The following is a description of a gene set: from publication Hu X, Chung AY, Wu I, Foldi J, Chen J, Ji JD, Tateya T, Kang YJ, Han J, Gessler M, Kageyama R, Ivashkiv LB (PMID 18976936) Human Gene Set: GSE11864_UNTREATED_VS_CSF1_IN_MAC_UP Gene expression analysis of freshly isolated CD14+ human monocytes and monocytes cultured in the presence or absence of interferon (IFN) -gamma for 24 h and then stimulated with Pam3Cys, a Toll-like receptor (TLR) 2 ligand, for 6 h. Results provide insight into mechanisms by which IFN-gamma reprograms early macrophage differentiation and subsequent response to TLR ligands. Genes up-regulated in comparison of untreated macrophages versus those cultured with M-CSF. studied in species Homo sapiens, and this is the list of marker genes: C6orf58, PTK2, PGM1, SAMD4B, TGFB1, GOLM1, ATG4B, RWDD1, THOC5, EAF2, STEAP4, PTPN18, KBTBD11, SESN2, HNRNPK, ALDOC, TAFAZZIN, RYK, OLFML1, FDPSP2, SSX2IP, CD300LF (CD300 molecule like family member f), KCNMB1, TAF9B, FAM174B, KLF13, MZT2B, SF3B5, MTA1, RPS3, DNAJC10, EVI2B (ecotropic viral integration site 2B), FLT3, SRSF5, PEX16, PMPCB, ARHGAP15, PABIR3, SLC41A3, MEGF9, ALAS2 (NCBI Gene Id 90735), CMPK1, RELA, TPT1, RPS6, ARHGEF1, ZC3H15, LMNB1, KLHDC4, PSMA1, RPIA, HGS, CD52, TEX47, DOCK2, PLCB1, NFYC-AS1, ITPK1-AS1, ANKHD1, PIWIL4, HLX, ATP5MG, RPL37A, PLAAT4, FAM168B, CCDC6, PYM1, FAM200B, TXLNGY, PLN (NCBI Gene Id 5350), RPS9, INPP4B, HIC2, LYZ, DPYD, CREB5, P2RX1, ARPC1B, RPS28, GMFG (NCBI Gene Id 9535), ENPP6, PHB2, UBE2D3, NME8, IRAG2, UBA7, ZNF296, RAB1B, VCPKMT, STYXL2, NET1, GNB1, HHEX, CYC1, NOP2, CCDC181 (coiled-coil domain containing 181), PRKRA (protein activator of interferon induced protein kinase EIF2AK2), FASTK, MALT1, RPL35, ASGR1, RPL19, DOCK8, PDCD6P1, ACTR1A, SERTAD2, FOSL2, CCL17, RASGRP4, EEF2, RASGEF1A, EOLA1 (NCBI Gene Id 91966), SLAIN2, IFT81, ZNF598, HIPK2, TSTD2, FAM136A, HNRNPA3, ANXA1, SNHG32, SLITRK2, GAB2, LINC00877, RNF139, CDK2AP1, MIR1-1HG, HNRNPM, USP39 (NCBI Gene Id 10713), C4orf33, LIN7A, SKIC8, SMAD2, NAA10, UBXN11, CPA6, GTPBP4 (NCBI Gene Id 23560), MAN2C1, P4HA1, NTNG2, TP53INP1, CHMP1B, SPI1, ATG2A, RPL36A, ZDHHC3, POC1B, APOBEC3G, P2RY13, IZUMO1, IL12A, PSMD13, CENPC, GABARAPL1, TMEM87B, LRRC25, HDDC2, NOMO3, TMC6, SYNE3, CD300LB, HERPUD1 (homocysteine inducible ER protein with ubiquitin like domain 1), TAGAP, PTBP2, CHPF2, SMYD3, JUND, SVIL, KIAA0040, SSH2, TBC1D1, SMAD3, PABPN1, RNLS, RSL24D1, RPL22 (NCBI Gene Id 65281), LRCH4, LONRF3, NSA2, RBM6, FAM24A, ENSA, MAPK7, NDUFS7, AGRP, VPS53, SLC2A3, TAP2, ABHD14B, LINC01127, INAVA, LINC02907, FXYD6, OGFR (NCBI Gene Id 51783), RPL12, CAMLG